The following is a description of a gene set: studied in species Mus musculus from publication Mori S, Rempel RE, Chang JT, Yao G, Lagoo AS, Potti A, Bild A, Nevins JR (PMID 18922927) The Emu-myc transgenic mouse has provided a valuable model for the study of B-cell lymphoma. Making use of gene expression analysis and, in particular, expression signatures of cell signaling pathway activation, we now show that several forms of B lymphoma can be identified in the Emu-myc mice associated with time of tumor onset. Furthermore, one form of Emu-myc tumor with pre-B character is shown to resemble human Burkitt lymphoma, whereas others exhibit more differentiated B-cell characteristics and show similarity with human diffuse large B-cell lymphoma in the pattern of gene expression, as well as oncogenic pathway activation. Importantly, we show that signatures of oncogenic pathway activity provide further dissection of the spectrum of diffuse large B-cell lymphoma, identifying a subset of patients who have very poor prognosis and could benefit from more aggressive or novel therapeutic strategies. Taken together, these studies provide insight into the complexity of the oncogenic process and a novel strategy for dissecting the heterogeneity of B lymphoma. Down-regulated genes in the B lymphocyte developmental signature, based on expression profiling of lymphomas from the Emu-myc transgenic mice: the Large Pre-BII stage. Human Gene Set: MORI_LARGE_PRE_BII_LYMPHOCYTE_DN, and this is the list of marker genes: CD22, IL4R, RGS14, CTSH, LPP, IL2RG, RIPOR2, UBA7, GNS, PIP4K2A (NCBI Gene Id 5305), IL10RA, LAT2, RGL2, HLA-DMB, ALDH2, HLA-DMA, CTSS, WIPF1, ITGAV, IGKV1D-43, RASA3, PXK, SERPINB1, CNR2, DOCK2, CD83, CXCR5, CD74, LY86, SIPA1, NEAT1, HLA-DQA2, CAPG, ADCY7, MCL1, LCP1, PTPN6, BIRC3, CAPN1, IL4I1, SAMHD1, MACF1, GPR65, CRYBG1, IRF8, VCAM1, HIP1R, DTX1, GGA2, SCD, BTG1, SLC25A53, PTPRC, SEMA4D (NCBI Gene Id 349236), GMIP (NCBI Gene Id 51291), SNAPIN, SOAT1, MS4A1, LTB, CD79B